The following is a description of a gene set: Oxidized phospholipids are thought to promote atherogenesis by stimulating endothelial cells (ECs) to produce inflammatory cytokines, such as IL-8. In studies with mouse models, we previously demonstrated that genetic variation in inflammatory responses of endothelial cells to oxidized lipids contributes importantly to atherosclerosis susceptibility. We now show that similar variations occur in cultured aortic ECs derived from multiple heart transplant donors. These variations were stably maintained between passages and, thus, reflect either genetic or epigenetic regulatory differences. Expression array analysis of aortic EC cultures derived from 12 individuals revealed that >genes were regulated by oxidized phospholipids. We have used the observed variations in the sampled population to construct a gene coexpression network comprised of 15 modules of highly connected genes. We show that several identified modules are significantly enriched in genes for known pathways and confirm a module enriched for unfolded protein response (UPR) genes using siRNA and the UPR inducer tunicamycin. On the basis of the constructed network, we predicted that a gene of unknown function (MGC4504) present in the UPR module is a target for UPR transcriptional activator ATF4. Our data also indicate that IL-8 is present in the UPR module and is regulated, in part, by the UPR. We validate these by using siRNA. In conclusion, we show that interindividual variability can be used to group genes into pathways and predict gene-gene regulatory relationships, thus identifying targets potentially involved in susceptibility to common diseases such as atherosclerosis. from publication Gargalovic PS, Imura M, Zhang B, Gharavi NM, Clark MJ, Pagnon J, Yang WP, He A, Truong A, Patel S, Nelson SF, Horvath S, Berliner JA, Kirchgessner TG, Lusis AJ (PMID 16912112) Genes from the grey module which are up-regulated in HAEC cells (primary aortic endothelium) after exposure to the oxidized 1-palmitoyl-2-arachidonyl-sn-3-glycerophosphorylcholine (oxPAPC). Human Gene Set: GARGALOVIC_RESPONSE_TO_OXIDIZED_PHOSPHOLIPIDS_GREY_UP studied in species Homo sapiens, and this is the list of marker genes: ADAMTS1, ZSCAN31, ARRDC4, FNIP1, HERPUD2, INSIG1-DT, ADAMTS9, NHSL3 (NHS like 3), CCDC68, RORA, NAV3, DUSP5, LBH, IRAK2, SOS1, TFEC, CREBRF (NCBI Gene Id 153222, CREB3 regulatory factor), TRIM16